Given this list of marker genes CEBPD, PRKCD, PTPN1, UVRAG, RBMS1, MET (MET proto-oncogene, receptor tyrosine kinase), TBL1X, CDK14, JUND, FOXD1, RRAS2, TNFRSF1A, CDK8, FBXO46, SPOP, PMP22 (NCBI Gene Id 5376), STX7, PLPP3, EMG1, CTDSP2, CASP8, RARS1, LSM2, NIPSNAP2, NDUFV2, IL4R, EFCAB14, PGRMC2, EAPP, CUL1, RABGAP1, TLE1, PUDP, RAB11A, TRIP10, MORC3, NASP, here is a description of the gene set: species: Homo sapiens Cluster d7: genes progressively down-regulated in WS1 cells (fibroblast) through 18 h after irradiation with high dose UV-C. from publication Gentile M, Latonen L, Laiho M (PMID 12907719) DNA damage caused by UV radiation initiates cellular recovery mechanisms, which involve activation of DNA damage response pathways, cell cycle arrest and apoptosis. To assess cellular transcriptional responses to UVC-induced DNA damage we compared time course responses of human skin fibroblasts to low and high doses of UVC radiation known to induce a transient cellular replicative arrest or apoptosis, respectively. UVC radiation elicited >3-fold changes in 460 out of 12,000 transcripts and 89% of these represented downregulated transcripts. Only 5% of the regulated genes were common to both low and high doses of radiation. Cells inflicted with a low dose of UVC exhibited transcription profiles demonstrating transient regulation followed by recovery, whereas the responses were persistent after the high dose. A detailed clustering analysis and functional classification of the targets implied regulation of biologically divergent responses and suggested involvement of transcriptional and translational machinery, inflammatory, anti-proliferative and anti-angiogenic responses. The data support the notion that UVC radiation induces prominent, dose-dependent downregulation of transcription. However, the data strongly suggest that transcriptional repression is also target gene selective. Furthermore, the results demonstrate that dose-dependent induction of cell cycle arrest and apoptosis by UVC radiation are transcriptionally highly distinct responses. Human Gene Set: GENTILE_UV_RESPONSE_CLUSTER_D7